The following is a description of a gene set: The directed movement of a protein to a specific location in a postsynaptic membrane. Mouse Gene Set: GOBP_ESTABLISHMENT_OF_PROTEIN_LOCALIZATION_TO_POSTSYNAPTIC_MEMBRANE species: Mus musculus, and this is the list of marker genes: Gripap1, Cplx1, Arhgap44, Scrib, Sacm1l (SAC1 suppressor of actin mutations 1-like (yeast)), Lrrc7, Epb41l1 (erythrocyte membrane protein band 4.1 like 1), Stx1b, Rab8a, Mapk10, Snap47, Stx3, Stx4a, Snap23, Rapsn, Mylk, Vps35, Clstn1, Rab11a, Nsg1, Grip1, Grip2, Vamp2